The following is a description of a gene set: Cytokines mediate cell-cell communication in the immune system and represent important therapeutic targets. A myriad of studies have highlighted their central role in immune function, yet we lack a global view of the cellular responses of each immune cell type to each cytokine. To address this gap, the authors created the Immune Dictionary, a compendium of single-cell transcriptomic profiles of more than 17 immune cell types in response to each of 86 cytokines (>1,400 cytokine-cell type combinations) in mouse lymph nodes in vivo. A cytokine-centric view of the dictionary revealed that most cytokines induce highly cell-type-specific responses. For example, the inflammatory cytokine interleukin-1β induces distinct gene programmes in almost every cell type. A cell-type-centric view of the dictionary identified more than 66 cytokine-driven cellular polarization states across immune cell types, including previously uncharacterized states such as an interleukin-18-induced polyfunctional natural killer cell state. from publication Cui A, Huang T, Li S, Ma A, Pérez JL, Sander C, Keskin DB, Wu CJ, Fraenkel E, Hacohen N (PMID 38057668) Genes negatively differentially expressed in cell type: γδ T cell upon treatment with cytokine: TL1A in mouse lymph nodes in vivo. species: Mus musculus Mouse Gene Set: CUI_T_CELL_GD_TL1A_RESPONSE_DN, and this is the list of marker genes: Cebpb, Cited2, Tmem50a, Nt5e, Btg2, Kbtbd11, S100a10, Crip1, Dusp5, Klf6, Hcst, Ckb, Ypel3, Selplg, Pnrc1, Cd53, Hmgb2, Cd7, Fos, Rgcc, Stk17b, Ramp3, Rgs2, Saraf, Klf2, Itgb7, Serpinb1a, Coq10b, Emb, Ifngr1, Lpar6, Ptpn18, Fosl2, Smpdl3a, Sdc1, Cox7a2l, Nr4a1, Vim, Cytip, Paip2, Ctsd, Dusp1, Icos, Gmfg, Gpr183, Septin9, Mbnl1, Pdcd4, Ppp1r12a, Ubc, Kcnc1, Cd3g, Klrk1, Jund, Igf1r, Rgs10, Ptk2b, Egr1, Ucp2, Skap1, Kcnk1, Jun, Faah, Fxyd5, Satb1, Zfp36l2, H3f3b, Ablim1, Junb, Txnip, Syne1 (NCBI Gene Id 64009), Lmo4, Rsrp1, Tspo, Anxa1, Cd3e, Tmem64, Ddx5, S100a6, Ncor1, Jaml